The following is a description of a gene set: studied in species Mus musculus Cytosine methylation of mammalian DNA is essential for the proper epigenetic regulation of gene expression and maintenance of genomic integrity. To define the mechanism through which demethylated cells die, and to establish a paradigm for identifying genes regulated by DNA methylation, we have generated mice with a conditional allele for the maintenance DNA methyltransferase gene Dnmt1. Cre-mediated deletion of Dnmt1 causes demethylation of cultured fibroblasts and a uniform p53-dependent cell death. Mutational inactivation of Trp53 partially rescues the demethylated fibroblasts for up to five population doublings in culture. Oligonucleotide microarray analysis showed that up to 10% of genes are aberrantly expressed in demethylated fibroblasts. Our results demonstrate that loss of Dnmt1 causes cell-type-specific changes in gene expression that impinge on several pathways, including expression of imprinted genes, cell-cycle control, growth factor/receptor signal transduction and mobilization of retroelements. Mouse Gene Set: JACKSON_DNMT1_TARGETS_UP Genes up-regulated in MEF cells (embryonic fibroblast) upon Cre-lox knockout of DNMT1. from publication Jackson-Grusby L, Beard C, Possemato R, Tudor M, Fambrough D, Csankovszki G, Dausman J, Lee P, Wilson C, Lander E, Jaenisch R (PMID 11137995), and this is the list of marker genes: H2-M3, Ptgs2, Map2k3, Igfbp6, Traf3, Thbs2, Eif3a, Trim25, H2-Q5, Ifngr1, Rhox5, H2-D1, Ect2, Chek1, Cyp2e1, Cryab, H2-T10, Irf7, Pdgfa, Rela, Gpr12, Etv4, H2-T23, Ifi202b, Eif2ak2, D17H6S56E-5, Nfe2l2, Cxcl1, Eng, Bin1, Socs3, Dazl, Prl3d1, Mx2, Jak2, Hif1a, Sin3a, Dynlt2a1, Traf4, Trim28, Ccl2, Xlr3a, Ackr3, Sfrp1, Sema3c, Junb, Ccng2, Il10rb, Epha2, Rad52, Hmga1, Isg15, Gata2, H2-K1, Rpa2, Csf1, Bag1, Zfp64, Cdc25a, Hspb1, Tsg101, Mre11a, Parp1, Cdkn1a, Ccn1, Ifit3, Ctnnb1, Tk1, Plin2, Reep5, Ahcyl, Zfp36, Hsph1, Slbp, Ereg, Il1rap, Csk, Slpi, Cebpz, Klf4, Ifi203, Ifit1, Procr, Phlda1, Tdg, Rgs16, Polr2a, Gtf2h1, Xist, Cxcl10, Tgoln1, Fgfr1